The following is a description of a gene set: This term describes abnormality of the white matter of the cerebrum resulting from damage to the myelin sheaths of nerve cells. Leukoencephalopathy studied in species Homo sapiens Human Gene Set: HP_LEUKOENCEPHALOPATHY, and this is the list of marker genes: NAXE, NDUFS7, NRROS, HTRA1, MEF2C, TRPM3, ACP5, EOGT, LAMA1, POT1, AP4B1, ERCC2, COLGALT1, ARID2, RNASET2, LYRM7, ZFX, CTC1, ATP13A2, LONP1, POMT2, SURF1, NDUFV1, UBA1, CNP, PPFIBP1, NDUFS2, MT-ND2, INTS11, NFE2L2, PUF60, ABCC9, DNM1L, CLPB, EIF2B2, HIKESHI, AARS1, POMT1, TARS1 (NCBI Gene Id 94887), STXBP1, YME1L1, DOCK6, CLCN2, SUCLG1, OPA1, RBPJ, AMPD2, EARS2, PMPCB, GM2A, SNORD118, NDUFAF3, KDM5A, FOXRED1, GNB2, SDHA, WARS1, SAMHD1, AIFM1, PLAA, RFWD3, CTBP1, MT-TN, NDUFS3, MLC1, FKRP, CPLX1, COL4A1, NRCAM, PIGA, HEPACAM, CDC42, LMX1B, OCRL, COA8, AP4S1, CDK13, TREM2, NDUFB10, TMEM126B, RNU4-2, NDUFB11 (NCBI Gene Id 54539), PRORP, B3GALNT2 (beta-1,3-N-acetylgalactosaminyltransferase 2), TTC5, NDUFAF8, TIMMDC1, SUGCT, HIBCH, NOTCH1, AARS2, GTF2E2, NUBPL, PAK1, EIF2B3, FBXL4, FCSK, ODC1, SUMF1, SCO2, TET3, AHDC1, RNU7-1, NFU1, NDUFS8, HMGCL, NDUFAF2, RPIA, TSEN54, TBCK, TRMT1, RAB3GAP2, RTTN, RAC1, AUH, GMPPB, PDHA1, AP4M1, MRPS22, GTF2H5, FGFRL1, RPL10, DDHD2, ABHD16A, RRM2B, NDUFB3, MT-ND1 (NCBI Gene Id 4535), L2HGDH, NOTCH2NLC, DPM3, SPG11, STRADA, ESAM, ABCD1, SEPSECS, GFAP (NCBI Gene Id 2670), PRR12, WARS2, NDUFAF1, NDUFV2, SSR4, LARGE1, TYROBP, TMEM222, TYMP, ARHGAP31, DEGS1, KARS1, CSF1R, CYP27A1, ARSA, SCP2, FA2H, CLN6, NDUFS4, EIF2B1, NSD2, FARSA, AFG2B, AP4E1, ACTL6B, LIPT2, NDUFB9, PDHB, DARS1, ASL, PSAP, MMACHC, CNKSR2, TREX1, PRNP, MARS2, NEUROD2, NDUFA1, HK1, ALDH18A1, SDHAF1, SPG21, SELENOI, SON, POLG, NDUFS1, RNF113A, ALG8, NDUFS6 (NCBI Gene Id 4726), MORC2, PC, KCNN2, MPV17, NDUFC2, NDUFAF4, SCN4A, MPLKIP (M-phase specific PLK1 interacting protein), SNF8, CTCF, TMEM70, COA7, USP7, NDUFAF5, KIF5A, PDHX, NDUFA11, ERCC3, DLL4, CARS1, LAMB1, GALC (NCBI Gene Id 2581), CLCN4, BRF1, CNBP, ACTA2 (NCBI Gene Id 59), TPRKB, VPS11, NOTCH3, EIF2B4, LIG3, ISCA2, CNTNAP2, UQCC3, CA2, NMNAT1, DARS2, MT-ND3, AP5Z1, SHANK3, DPM2, LETM1, MTHFR, EDEM3, NDUFA6